Given this list of marker genes PITPNB, CA9, SUMO3, SLC35G1, PPP1R7, ATPAF1, TTK, DNAJC10, PEG3, USP1, SLC22A4, IFT27, UQCRC2, GRHL2, GAS2, CSTF2, ASF1A, ANTKMT, DEPTOR, BTG3, CHST11, GLRX5, GP9, MCM7, MARS1 (methionyl-tRNA synthetase 1), ACY1, FAM98A, SIK2, DDX19A, F5, MRPL2, CHAF1B, SUPV3L1, TIMM10, ZC4H2, SLC7A1, FAM216A, DMAC2L, CCDC51, TXNL1, SEC11A, NAA10, SMO, CTBS, DHRS4, SLC1A4, HACD1, BLM, BEND3, CWC27, NIPA1, NUP155, ICE2, B3GNT2, PCCA, FARSA, ARMCX4, CCT6A, FAM171A1, ILF2, RPAP3, BABAM2, TMED5, HSP90AA1 (NCBI Gene Id 89272), CYP11A1, RTEL1, MMS22L, AKAP1, MTG1, PRRC1, PEX7, BMI1, GPX3, TCN2, PTPN4, ZC3H14, TICRR, CAMK1, PSPH, WEE1, MPP3, TMEM38B, GRB10, PBK, MINDY1, GALC, PCGF6, CLDN15, NIN, NAE1, MEGF9, MCU, C14orf119, ITGB3BP, NUP54, PRR3, PPP5C, PTGR2, OTOS, RASA2, KLHL12, C6orf136, CLPB, ATRN, HGF, GCHFR, CDC6 (NCBI Gene Id 990), DUS1L, PEX11A, RMND1, FCF1, CDK5R1, DGCR8, NPM3, F13A1, MTNAP1, SPAG4, WDR55, STT3A, SULT1B1, MTFR1L, AK1, SASS6, PGM2, TOMM7, NAA35, SPRY2, SCCPDH, DDX54, RHBDF1, MTHFD2, ATP6V1E1, QSOX2, NUDCD1, RAD51AP1, RAB3GAP2, ORC6, MYCBP, AK3, FKBP1A (NCBI Gene Id 2280), DET1, UTP14A, RDH13, SEPSECS, SLC26A6, METTL18, DUS3L, PADI4, MMP8, FRMD6, HSPD1, UROS, CKAP2L, AIRN, MPP7, COQ4, ABHD11, KATNBL1, MUSK, DNAI4, CDC23 (cell division cycle 23), C1QBP, GSTM4, KIF20B, EAF1, LCMT1, COQ6, CNDP2, RPL23, AMACR, UQCRB, WDR76, PABIR1, PATZ1, LRRC8D, SETD4, FLOT2, HACD3, SLC25A39, KDSR, CNOT2, SDHA, FAM221A, METTL6, TMEM192, DLEU7, TARS3, CRYL1, THADA, CLEC4E, EPB41, BUB3, MPP1 (NCBI Gene Id 4354), PITRM1, MIGA1, SFMBT2 (Scm like with four mbt domains 2), UBE2T, HEBP1, ZBTB44, PIP5K1B, here is a description of the gene set: species: Homo sapiens Human CD14 positive monocytes were purified from healthy volunteers’ blood and cultured in vitro for 4, 12, 24, 72 hours. While culturing, macrophages were activated alternatively with interleukin-4 (IL-4 100 ng/ml) or classically with interferon-gamma (IFNg 100 ng/ml)+tumor necrosis factor (TNF 50 ng/ml) or left without activation. Simultaneously, macrophages were also treated with vehicle (DMSO:ethanol) or 1mM synthetic PPARg agonist, Rosiglitazone. We used Affymetrix microarrays (U133Plus 2.0) to analyze activation and PPARg-induced gene expression changes. from publication Szanto A, Balint BL, Nagy ZS, Barta E, Dezso B, Pap A, Szeles L, Poliska S, Oros M, Evans RM, Barak Y, Schwabe J, Nagy L (PMID 21093321) Human Gene Set: GSE16385_ROSIGLITAZONE_IL4_VS_ROSIGLITAZONE_ALONE_STIM_MACROPHAGE_DN Genes down-regulated in macrophages (12h): rosiglitazone and IL4 versus rosiglitazone.